The following is a description of a gene set: from publication Järvinen AK, Autio R, Haapa-Paananen S, Wolf M, Saarela M, Grénman R, Leivo I, Kallioniemi O, Mäkitie AA, Monni O (PMID 16715129) studied in species Homo sapiens Molecular mechanisms contributing to initiation and progression of head and neck squamous cell carcinoma are still poorly known. Numerous genetic alterations have been described, but molecular consequences of such alterations in most cases remain unclear. Here, we performed an integrated high-resolution microarray analysis of gene copy number and expression in 20 laryngeal cancer cell lines and primary tumors. Our aim was to identify genetic alterations that play a key role in disease pathogenesis and pinpoint genes whose expression is directly impacted by these events. Integration of DNA level data from array-based comparative genomic hybridization with RNA level information from oligonucleotide microarrays was achieved with custom-developed bioinformatic methods. High-level amplifications had a clear impact on gene expression. Across the genome, overexpression of genes could be attributed to gene amplification events in cell lines, with genes showing the same phenomenon in primary tumors including FADD and PPFIA1 at 11q13. The analysis of gene ontology and pathway distributions further pinpointed genes that may identify potential targets of therapeutic intervention. Our data highlight genes that may be critically important to laryngeal cancer progression and offer potential therapeutic targets. Genes whose expression was increased due to copy number gain in laryngeal cancer tumors (both in primary cultures and cell lines). Human Gene Set: JAERVINEN_AMPLIFIED_IN_LARYNGEAL_CANCER, and this is the list of marker genes: PIP4P1, BRF2 (NCBI Gene Id 55290), LSM1 (NCBI Gene Id 27257), GTPBP8, COPS5, KDM5A, PSCA, MGAM (NCBI Gene Id 8972), DVL3, C2CD3, PLCH2, C11orf68, COQ4, PSMB5 (proteasome 20S subunit beta 5), PPFIA1, FAM220A, NDUFB5, CCT5, MYCBP2, NR1I3, ASH2L, TOPBP1, SNRPD3, ENTPD2, TRIP13, DDX31, GPATCH2L, MCCC1, FADD, ERLIN2, PARP4 (NCBI Gene Id 221181), MORN1, DUSP16, ZBTB25, KLHL7, GNPAT (NCBI Gene Id 8443), ESR1, NPL, C1orf131, PLGRKT